The following is a description of a gene set: TNF receptor superfamily (TNFSF) members mediating non-canonical NF-kB pathway Mouse Gene Set: REACTOME_TNF_RECEPTOR_SUPERFAMILY_TNFSF_MEMBERS_MEDIATING_NON_CANONICAL_NF_KB_PATHWAY species: Mus musculus, and this is the list of marker genes: Traf2, Tnfrsf12a, Xiap, Map3k14, Birc2, Traf3, Cd40, Tnfsf14, Tnfrsf11a, Cd40lg, Tnfsf13b, Tnfsf12, Ltbr, Tnfsf11, Birc3, Ltb, Tnfrsf13c, Lta (NCBI Gene Id 16992)